Given this list of marker genes TGFBR2, ACVR2A, ACVR1B, ENG (endoglin), ACVRL1, ACVR1, ACVR2B, FSTL3, TGFBR3, TGFBR1, FST, here is a description of the gene set: Human Gene Set: GOMF_ACTIVIN_BINDING Binding to activin, a dimer of inhibin-beta subunits. studied in species Homo sapiens